Given this list of marker genes Pld4, Ctps1, Nabp1, Ccl5, Wars1, Csf1r, Orm1, Mcm4, Gm33887, Pkm, Tgtp1, Sptlc2, Tyrobp, Pld3, Bcl2a1a, Mt1, Il18bp, Qsox1, Mt2, Slfn2, Mpeg1, Plac8, Snx10, Tspan4, Lck, Ncf4, Stx3, Lrg1, Cd74, Gdf5, Lilrb4b, Fcgr1, Scmh1, Gbp3, Ctla2b, H2-DMa, Traf3ip2, Hpx, Lcp2, Tff3, Fgl2, S100a11, Ear1, Sult2a1, S100a6, Grn, Scd2, Stat1, Rras, Cd52, Lgmn (legumain), Sirpa, Plk1, C1qc, Gltp (glycolipid transfer protein), Cyba, Cyp26a1, Iqgap1, Trbc1, Tmsb10, Lbp, D17H6S56E-5, Ncoa3, Pira1, Btg2, Sh3gl1, Ptprc, Atp1b3, Itgb2, Mcrs1, Gpx3, Ltf, Rnd2, Prtn3, Nfkbiz (nuclear factor of kappa light polypeptide gene enhancer in B cells inhibitor, zeta), Saa3, Ear2, Cd5l (CD5 antigen-like), Slpi, Cd53, Pdk3, Cfp, Hck, C1qa, Ptpn1, Ccl2, H2-DMb1, Rbm3, Ifi47, Casp1, Ms4a6c, Camp, Cd68, Cxcl9 (NCBI Gene Id 17329), Ccl4, Samhd1, Clic1, Mmp12, Orm3, Marveld1, Prom1, Tapbp, Msr1, Cybb, H2-Q10, Tap1, Psmb9, Cxcl1, Cd14, S100a9, Ifi205, Ccr1, S100a4, Serpina3g, Orm2, Fpr1, Nampt, Adgre1, Cytip, Tmsb4x, Apbb1ip, H2-Eb1, Vcam1, Aif1, H2-Aa, Cd7, Birc5, Ubd, Lpl, Ctsc, Smoc2, Ngp, H2-Ab1, Gbp2, Ms4a4d, Pirb, Lyz2, Colgalt1, Lgals3, Dclre1a, Nnmt, Tlr6, Litaf, Procr, S100a8, Selplg, Irgm1, Snx12, Nop2, Chil3, C1qb, Cyb561, Laptm5, Shisa5, Ctss, here is a description of the gene set: species: Mus musculus The liver, skin, and gastrointestinal tract are major target organs of acute graft-versus-host disease (GVHD), the major complication of allogeneic bone marrow transplantation (BMT). In order to gain a better understanding of acute GVHD in the liver, we compared the gene expression profiles of livers after experimental allogeneic and syngeneic BMT using oligonucleotide microarray. At 35 days after allogeneic BMT when hepatic GVHD was histologically evident, genes related to cellular effectors and acute-phase proteins were up-regulated, whereas genes largely related to metabolism and endocrine function were down-regulated. At day 7 after BMT before the development of histologic changes in the liver, interferon gamma (IFN-gamma)-inducible genes, major histocompatibility (MHC) class II molecules, and genes related to leukocyte trafficking had been up-regulated. Immunohistochemistry demonstrated that expression of IFN-gamma protein itself was increased in the spleen but not in hepatic tissue. These results suggest that the increased expression of genes associated with the attraction and activation of donor T cells induced by IFN-gamma early after BMT is important in the initiation of hepatic GVHD in this model and provide new potential molecular targets for early detection and intervention of acute GVHD. Mouse Gene Set: ICHIBA_GRAFT_VERSUS_HOST_DISEASE_35D_UP from publication Ichiba T, Teshima T, Kuick R, Misek DE, Liu C, Takada Y, Maeda Y, Reddy P, Williams DL, Hanash SM, Ferrara JL (PMID 12663442) Hepatic graft versus host disease (GVHD), day 35: genes up-regulated in allogeneic vs syngeneic bone marrow transplant.